The following is a description of a gene set: Mouse Gene Set: REACTOME_SMOOTH_MUSCLE_CONTRACTION Smooth Muscle Contraction studied in species Mus musculus, and this is the list of marker genes: Tpm2, Tpm3, Gucy1b1, Myl6, Cald1, Itga1, Pxn, Myl6b, Myh11, Calm1, Tpm1, Actg2, Lmod1, Tpm4, Gucy1a1, Myl7, Pak2, Vcl, Acta2, Myl10, Calm3, Tln1 (NCBI Gene Id 21894), Sorbs1, Pde5a, Mylk, Pak1, Sorbs3, Mylpf, Gucy1b2 (guanylate cyclase 1, soluble, beta 2), Myl12b, Myl9, Calm2, Gucy1a2